The following is a description of a gene set: studied in species Mus musculus Any process that results in a change in state or activity of a cell or an organism (in terms of movement, secretion, enzyme production, gene expression, etc.) as a result of a luteinizing hormone stimulus. Mouse Gene Set: GOBP_RESPONSE_TO_LUTEINIZING_HORMONE, and this is the list of marker genes: Ccna2, Ednra, Edn1, Star, Tgfbr3, Npr2, Cyp1b1, Lhcgr